Given this list of marker genes DCDC2, TGFBI, RUNX1T1, USP37, PREP, TBL1X, KDM4A, OXR1, RAB30, SYT4, NPR3, GNG2, PLEKHA8, NRG3, ATG14, DNAJC21, TMEM127, POU2F2, CRHR2, EDEM3, GNB1, SNX1, HIVEP2, RETNLB, CTNNA1, PMP22, RAB27B, RAB11FIP5, ZNF304, VANGL1, LPGAT1, PTP4A2, BBX, HIC2, WDR72, THRAP3, HEPHL1, CIT, FGF18, MYOCD, CENPP, ARMC8, THRA, ENSG00000255537, PTCD3, LRP8, ARFGEF2, WDFY3, SLC8A1, SHROOM4, WIPF3, EIF2S2, MYD88, CCDC148, ABCC1, MAK16, SLC35F1, YPEL2, CD2AP, UBXN7, GRIA4, EIF5B, DYNLL2, SMURF2, CACNG3, LURAP1L, PHF20L1, TNKS, ACSL1, STAT4, MTMR10, BTBD10, ZBTB43, RASSF8, GRAMD2B, PLP1, USP48, GOLPH3L (golgi phosphoprotein 3 like), FLRT3, NET1, CUX2, ZHX3, SYNC, RYBP, CCL11, GUCY1A2, C2orf15, UBLCP1, FNTB, CHMP5, GOT2, RBM12, TBL1Y, RAB18, WLS, ST8SIA3, FAHD1, NSL1, FHIP2A, CBFA2T2, FBN1, RALBP1, CARM1, FRMD6, UBE4A, FZD10, CMTM6, MDGA2, DISC1, STXBP5L, TRPC3, AK9, TPK1, CCSAP, GK, OSBPL6, RIC1, KIAA1549, MAP1A, TBC1D8, TAB3, WNK1, SNTG1, CTTNBP2, KLHL18, PITX2, RBPMS2, EPHB1, AP1S2, C2orf66, TCERG1, RBMS3, MTHFS, HACD4, DHX40, HK2, AGTR2, CD34, NEMP1, SART1, GJA3, CTTNBP2NL, BCL2L10, JPH1, ZNRF2, NR2F6, ARMCX5, PUS10, ONECUT2, PLPPR4, APOBEC4, IL5RA, TTC17 (tetratricopeptide repeat domain 17), ONECUT1, CSGALNACT1, CDH20, ZNF268, NR2E1, REM2, CCDC88C, MICOS10, MYBL1, VEGFA, IKZF3, SLC4A4, CCAR2, LYPLA1, CTDNEP1, PLEKHG7, CACNA2D3, ELOA, PPM1B, TLK1, DEUP1, ITGBL1, POLR3A, TTYH2, DDHD2, UHMK1, LCA5, BCAT1, NAA30, HDGFL3, CNPY2, PLAC8, CPPED1, SIK3, NFASC, RNF19A, SYT9 (NCBI Gene Id 337992), WDR82, PRKG1, ZBTB20, ST20-MTHFS, MEX3A, TEAD1, CSNK1G3, TRMT13 (tRNA methyltransferase 13 homolog), TTC29, KATNBL1, PALM2AKAP2, SORL1, DPH5, SGIP1, RANBP9, SRP68, RSAD2, LRRTM2, KCNB1 (potassium voltage-gated channel subfamily B member 1), ALG2, CSNK1G2, TARDBP, MBNL1, STX16, ZFHX3, VEZF1, PHF21A, PPM1L, here is a description of the gene set: species: Homo sapiens Human Gene Set: MIR29B_2_5P from publication Chen Y, Wang X (PMID 31504780) Genes predicted to be targets of miRBase v22 microRNA hsa-miR-29b-2-5p in miRDB v6.0 with MirTarget v4 prediction scores > 80 (high confidence targets).